The following is a description of a gene set: Reactome Pathway: Defects of contact activation system and kallikrein-kinin system The contact activation system (CAS) is a plasma serine protease cascade, which involves surface-induced interactions among factor XII (FXII or Hageman factor), prekallikrein (PK), and kininogen (high molecular weight kininogen, HMWK) in response to various stimuli such as tissue injury, toxic compounds, or microbial infection. Activated components of CAS coordinate inflammatory signaling pathways, complement activation, coagulation and fibrinolysis.<p>Abnormal activation of FXII is implicated in the pathogenesis of various diseases including hereditary angioedema (HAE) and Alzheimer’s disease (AD), though the mechanisms and consequences differ.<p>In HAE, uncontrolled activation of FXII-dependent kallikrein-kinin system (KKS) and excessive release of bradykinin from HMWK is usually associated with defective function of SERPING1 (C1-INH), a major regulator of the contact system (Suffritti C et al. 2014). More rarely, HAE occurs in individuals with normal SERPING1 activity, and has been linked to mutations in other proteins, including FXII (Cichon S et al. 2006; Magerl M et al. 2017; Zuraw BL & Christiansen SC 2016; Ivanov I et al. 2019). The proinflammatory byradykinin causes vasodilation and increased vascular permeability at the level of the post capillary venule, resulting in angioedema (Bossi F et al. 2009; Kaplan AP 2010; Suffritti C et al. 2014).<p>In AD patients, aggregated amyloid beta (Aβ) peptides provide a negatively charged surface that facilitates the binding and activation of factor XII (FXII) (Joseph K et al., 1999; Bergamaschini L et al., 2001; Zamolodchikov D et al., 2015). Enhanced FXII activation and downstream effects on the kallikrein-kinin system contribute to vascular dysfunction, prothrombotic state, neuroinflammation, and cognitive decline associated with AD pathology (Zamolodchikov D et al., 2015, 2016; Chen ZL et al., 2023; reviewed by Kaplan AP et al., 2024). Both PK and FXIIa are recognized as upstream triggers of the coagulation system. However, the clinical significance of these factors in thrombosis and hemorrhage is not fully understood. Blockade of the contact activation system (CAS) results in prolonged coagulation times in the activated partial thromboplastin time (aPTT) assay. Nevertheless, the absence of thrombotic or hemostatic abnormalities in individuals with genetic deficiencies of PK or FXII suggests that the CAS plays a minimal role in physiological coagulation (Müller F et al., 2011). However, it may contribute to thrombus formation under pathological conditions (Zamolodchikov D et al., 2016).<p>Genetic variants are named following Human Genome Variation Society (HGVS) nomenclature with sequence numbering starting from the first methionine of the protein as +1 (Goodeve AC et al.2011). part of: Diseases of Immune System studied in species Homo sapiens, and this is the list of marker genes: KLKB1, F12, F2, APP, SERPING1